The following is a description of a gene set: species: Homo sapiens Linoleic acid (LA) metabolism Human Gene Set: REACTOME_LINOLEIC_ACID_LA_METABOLISM, and this is the list of marker genes: ELOVL1, ABCD1, ELOVL2, FADS2, ELOVL3, ACSL1, ELOVL5, FADS1